The following is a description of a gene set: species: Homo sapiens Placenta genes. Human Gene Set: MODULE_38, and this is the list of marker genes: NNAT, TMED3, MAGEA4, PTGS1, TNFRSF10C, DHRS1, CDH1, IKBKG, RECQL5, MARF1, S100P, PDGFRB (NCBI Gene Id 5159), PRB4, DUSP5, DKK4, EGFR, ETS2, RAMP2, CRIM1, SMAGP, HSPB2, CAV1, DLK1, UPP1, SFTPC, TBC1D2B, S100A8, MYL9, GRK5, RAB31, GNE, TNF, COL3A1, PEG10, CDK2, TNFRSF1B, PSD4, ADRA1D, ECHS1, KRT7, HSD11B2, ARHGAP4, ZBTB7A, HMOX1, LTBP2, SCN1B, GPX3, MFAP2, NTSR2, S100A11, TRPC4AP, PTPN9, HSPA2, RBPMS, LGMN, ARID3A, LMO2, TOB2, LAPTM5, TGM2, TNR, CLEC3B, PTH1R, KRT19, DCAF7, CDK5R1, RAB4B (NCBI Gene Id 53916), CRIP1, RARRES2, SFXN3, PLXNA2, MCM2, KCTD17, IQSEC1, CCNE1 (cyclin E1), FSTL3, TIMP2, PLCB2, SERPINH1, FOSL2, ANPEP, SLC2A1, GJA4, STAB1, MAP2K3, IGFBP2, PDPN, TGFB1, CALU, PGF, DAB2, CGA, SLC4A2 (NCBI Gene Id 96677), TFAP2A, ADGRG6, PLA2G2A, CAD, SLC5A2, RGS10, RHOB, GPA33, AMELX, SLC16A3, CTSC, LRRC32, GABRE, CSF3R, GPNMB, COBLL1, HOXB3, TGFBI, MTHFR, LTBR, ERBB3, FCGRT, CCN1, MEN1, TACC2, ST3GAL4, TCF7, PAX4, CD34, IGFBP4 (insulin like growth factor binding protein 4), C2, CLDN4, JUNB, TGFBR3, FDXR, NCF4, FBLN1, ANK3, LY6G6C, LAMB2, PSG7, AQP5 (NCBI Gene Id 8084), TNXB, SMYD5 (SMYD family member 5), GJB1, APOC4, PTPRU, EPHB2, SCO2, ANXA1, IMPA2, PCOLCE, PLXND1, ITGA5, IL4R, TRIP10, DENND2B, ARL4C, CRYAA, CDH15, HCLS1, LAIR1, ITGB5, CRABP1, LAMA5, TFAP2C, TLE2, SMPDL3B, CNN3, COL1A1, HEG1, PER1, CLDN5, S100A9, NFYC, KDM5C, EMP2, CLIP2, PLK3 (polo like kinase 3), FN1, GAS1, ARHGEF16, SPP1, MAOA, PAX9, LRP1 (NCBI Gene Id 4035), PKP3, MGLL, CLN3, ELN, WAS, GPC3, DNAJB2, GADD45G, ABCA1, HSD17B1, TTLL12, MYH11, ADGRE5, WFS1 (NCBI Gene Id 94141), COL6A1, PDGFRA, PDXK, ACD, IL1R1 (NCBI Gene Id 3554), SH3BP1, SLCO2B1, TIMM17B, MYLK, PDGFB, CDC42EP1, TACSTD2, RIN1, ZYX, RHOBTB1, TPM1, HMOX2, CGB3, BMP1, POU2F2, SRCAP, LHB, QSOX1, CEACAM3, COL15A1, TLE1, HSPG2, IGFBP1, CXCL1, FOLR2, DNM2, DOK1, GATA3, CNKSR1, F13A1, BLVRB, GATA2, TIMP3, HAP1, FGR, LLGL2, AGPAT2, PPP6R2, EFNB1, ACOT2, RNASE1, BRD4, PRELID3A (NCBI Gene Id 10650), EMP3, RBP1, HSF1, MMP11, CDH5, TM4SF1, PNP, TPM2, IL32, TOM1, TRIP6, CYB5R1, EPAS1, FURIN, EDA, CCK, IGHG3, OCLN, DEPP1, ACTG2, SPINK2, ODF1, RUNX1T1, GRN, GDF15, IGSF3, HTR4, CLDN7, DAPK1, CKMT1B, FOXO4, CDKN1C, FLT1, ROR2, CDA, KIAA0513, DPT, PLIN2, TRPM2, TBX2, IGFBP3, CYP4B1, MSX1, MMP2, RAB11FIP5, POMZP3, MEST, ETV5, DDT, ERBB2, VAMP5, SLC38A10, TNFRSF25, PTGDS, ADCY3, LYN, NOTCH3, RHOD, ALDH3B2, TMEM63A, APOD, COL6A2, VPS11 (VPS11 core subunit of CORVET and HOPS complexes), AMOT, PTP4A3, SDC1, RRAD, FCGBP, PIM1, PKMYT1, H2BC12, ANXA8L1, HOPX, VWF, MAN2C1, PLEKHO2, NRG2, HPGD, DMTN, LTBP1, HRG, EFS, SEMA4D, DHRS3, SRPX, COL6A3, LGR5, AGXT, FLNA, GRB7, RHOBTB3 (NCBI Gene Id 22836), KCNN4, FGFR1, SLC23A2, SERPINB9, ATF3, DDX17, FCGR2B, COL5A2, GSE1, TRIM16, DTX4, JAG1, PSCA, ENG, IFI27, ZKSCAN7, MPP1, VSIG4, EFNA1, ENPP2, SEMA3F, GLRX, CCHCR1 (coiled-coil alpha-helical rod protein 1), CD151, PECAM1, FBN2, FAM107A, TNFAIP3, INHA, FBLN2, PHLDA2, CHPF, SCAMP5, ADM, MAPKAPK3, COL4A1, C1QB, ALAS2 (5'-aminolevulinate synthase 2), EDC4, CITED2, PRL, PROCR, KRT18, CFD, SLC29A1, PLAU, CRYAB, CCND1, TNFRSF10D, IER3, CYP11A1, KLHDC3, PFKFB2, TST, ATP6V0A1, TUSC3, NECTIN2, SOD3, PRKCZ, ADAM19, SLC7A8, CSPG4, INPPL1, LAD1, AAK1, POLA2, MVP, ITGB4, MFAP4, NEURL1, ALAS1, JAK3 (Janus kinase 3), PRSS8, FOSB, ETV3, M6PR, IGF2, SLC7A4, ITGA3, PPP1R15A, PCDH1, SOX10, CIAO1, IGF1, CHRNB1, MMP15, ITGA10, SLC18A3, TFAP2B, ECM1, DGKA, COL1A2, SMARCD2, ECE1, DSP, HES1, TUBGCP4, TRIM29, TNNT3, SLC6A2, SLC4A3, MEF2D, PPARD, AOC1, DUSP4, CD14, PRG2, KRT14, PLEC, DEFA3, APOE, LYPD3, PAX7, COL2A1, KRT86, LPCAT1, CDKN1A, ALDH4A1, ATOSB, MAFF, H2BC21, FOXD1, TEAD3, S100A4, TRAM2, SERPINE1, DOLK, CSF2RB, PTPRO, FUCA1, GNG11 (NCBI Gene Id 2791)